Given this list of marker genes CALML4, USP4, HAVCR1, CTDSP2, GIPC1, PRDM1, JADE1, HOXA7, PDE4D, FAM78A, SPAG7, MTTP, PTK2, ZFHX3, CREB3L1, NEBL, NDP, NR2F2, HRK, FGF13, KCNJ15, DDI1, SLC12A1, PACSIN3, POT1, FES, TNS1 (NCBI Gene Id 7145), DNAJB8, NHLH2, ATP1B4, CELF4, HAUS3, LHFPL1, PDHA2, SMOC1, RNF4, MSTN, SSTR1, PLIN2, TTR, CD55, ERN1, BCOR, PLIN1, FOXN3, AQP2, YIPF7, ATXN7L1, HNRNPD, AHNAK, CSF2, AMMECR1, ENSG00000228919, ATP13A4, ROBO1, PTPRO, ZNF423, TAF2, DOCK9, EPHA2, EBF2 (NCBI Gene Id 90868), S100PBP, CDX1, SLITRK2, NECAP1, RBMS1, TCF7L1, ABRAXAS2, PTH2R, JADE2, NOL4L, IRX4, NLGN2, SERPINA6, PCK1 (NCBI Gene Id 5105), MBNL2, PRG4, EXPH5, HOXB8, MFGE8, ZIC4, POLA1, SORCS1, DMP1, HTR2C, MITF, SOX12, JAZF1, TSHZ3, RARB, COL12A1, SKIDA1, PTGIR, PRDX5, SEMA4A, TMEM178A, SCN1A, ZNF503, SOBP, MNT, TRDN, H3-3B, SFN, SGIP1, TRAF3IP2, NF1, GATA3, CELF2, ERBB3, PRDM13, SLC8A3, CAPN12, ZNF532, VPS37B, LRCH1, MTMR11, KLF14, RHOJ, UBR5, KRT32, DCX, FLI1, LINC00472, S100G, GRM8, SHISA6, PAK1IP1, CDKL5, WNT11, MEA1, KRT23, PALS1, DPYD, RNF17 (ring finger protein 17), DCT, TIMELESS, COL4A6, BOC, HOXB5, TDRD5 (tudor domain containing 5), RAX, ACBD5, NPAS3, TSHZ1 (teashirt zinc finger homeobox 1), CDH6, SLC23A3 (solute carrier family 23 member 3), SGMS2, IL11RA, KLK3, OSR1, MYT1, FGF5, PLA2G2E, LMNA, FERD3L, PXYLP1, MYO15A, IL18, SLC5A10, SMIM8, SLC26A7, KIN, KRTAP19-2, GTF2A1L, NRP1, RPS6KB2, GMCL2, IP6K2, EYA1, MECOM, RUNX3, SLC41A2, SSBP3, GSE1, GRIA3, HSD3B7, SYT4 (synaptotagmin 4), NR1H4, ESRRG, TINAG, KALRN, SEC23B (SEC23 homolog B, COPII coat complex component), CYB5D1, ENOX1, EFNA5, STRN3, HOXA1 (NCBI Gene Id 3198), SLC6A4, HOXC13, ZHX2, TRMT10A, ENSG00000291228, SLC17A2, PAX9, KCND1, SF3B4 (splicing factor 3b subunit 4), PLXNA2, USP32, HOXD1, GRIK3, HOXA10, TPM2, C1QTNF7, CRLS1, FCHSD2, KCNMA1, LEMD1, UBE4B, GDF10, SHCBP1, SMPX, ACTC1, CHST15, BPHL, P2RY12, LLGL2, FAM193B, ADGRB2, NOB1, LBX2-AS1, DPF2, APRG1, GABRA1, ART4, KRTAP19-7, SLC6A20, IGFBP1 (NCBI Gene Id 3484), ACVR1, SV2A, TFAP2C, CNTLN, RREB1, CNIH2, NLGN3, ITGA9, FGF10, PDGFRA, MED13, PBX2, LMO3, TCF21, SSMEM1, LMO4, GDF7, TMEFF1, PCDHGB7, DLL1, DOCK11, SCML2, BNC2, BMP10, CLDN14, PCYT2, FBXL22, TUBB4A, NOS1, LRRN3, NAA38, POLE2, SOX4, ADAM22, KLHL41, LIX1, NSMCE3, EHF, MSI2, ABCA12, TMEM88, AMY2B, ANKRD28 (ankyrin repeat domain 28), PMEPA1, ADAMTSL2, PATZ1, RNF181, DUOX1, PHF21B, HOOK1, SP8, GNAQ, LBX1, KCTD5, GEMIN2, PRDM12 (NCBI Gene Id 59335), CSMD3, OTOP3, FZD4, TRERF1, CHST8, ETF1, SUPT16H, HS6ST2, PURA, CHM, GNRH1, ID3, NEO1, CDIN1, NRAS, RORB, TTYH1, COLQ, CCDC6, WNK1, PHYHIPL, PPP1R16B, ASCL4, BATF2, SLC5A1, BACH2, MPPED2, CHCHD7, CACNG8, NPTX2, KCNJ8, PRUNE2, MRPS18B, KCNIP2, FRZB, ENPP1 (ectonucleotide pyrophosphatase/phosphodiesterase 1), DLG2, DMD, HESX1, PCDH7, KLHL13, SYTL2, CCDC9B, PLAG1 (PLAG1 zinc finger), AP4S1, FEZF2, STAP1, TRPS1, NOL4, FOXB1, RUNX1T1, ZNF827, PRKD3, BAMBI, BHLHE22, CPNE5, PTGER1, RGS13, C1orf87, PALS2, GTPBP1, ROGDI, SSTR4, LHX6, HSPB8, GPR85, RHOBTB1, HOXB3, KIAA1191, KLHL1, ZMYM4, OPCML, FURIN, KRT2, HAND2, PRKCSH, SYTL4 (NCBI Gene Id 94121), STAT5B, FGF20, UNC13B, GSC, RIMOC1, SULF1, KCTD15, PLCD4, PTCH1, GC, KCNH2, NDUFA4, SATB2, RBBP8, CLOCK, EPHB6, SGCA, TMEM179, CYB561D1, ARHGAP18, PCNX4, ZBTB17, ADRA1B, CREB5, TGM6, FSTL1 (NCBI Gene Id 65385), INPP4B, PPP1R10, PABPC5, PIK3IP1, SFSWAP (splicing factor SWAP), NRN1L, RBFOX1, DDX49, ATP5F1C, LMNTD2, CKAP4, RTN4RL1, MCAM, DUSP6, MSRA, GRM3, ACBD6, SRSF2 (serine and arginine rich splicing factor 2), NR2F1, SLC5A2 (solute carrier family 5 member 2), MTF1, ZEB1, ALDH1A2 (aldehyde dehydrogenase 1 family member A2), CXCL14, NUDT21, CCER1 (NCBI Gene Id 196477), FAM117A, RINT1, NECAB3, CCIN, MGAT5B, PDYN, TTLL6 (tubulin tyrosine ligase like 6), EMX2, ALX3, ALG13, AQP11, CA4, NLRP7, RASSF2, GRID2, MARK1, PRKAB1, NFE2L1, GBX2, NSD1, HTR3B, RBMX (RNA binding motif protein X-linked), LRRC4, AQP5, HHIP, MTMR4, RASGRF2 (Ras protein specific guanine nucleotide releasing factor 2), SERPINI2, FRMD5, TACSTD2, KLHL4, CPS1, TLE4, RTN1 (NCBI Gene Id 8108), HOXD8, CLRN1, NPR3, TEX12, RELA, CLUH, KLHDC3, CDC6, NOVA1, CDKN2B, APBA1, ASB4, VAT1, PCNX1, TUBE1, HOXD3, GOLT1A, PKP3, BAZ1A, SLC34A3, MACROH2A1, MARCHF6, UBE2C, NONO, PPP3CB, SLC39A5, TGIF1, HOXB6, GPC4, TERB1, LSM11, FOXP2, COPE, NEUROD6, PITX2, SOX5, TENM1, FGF6, SLC26A3, COL9A1, POU3F4, KCNIP4, KRT81, TRMT112, PYGO2, TMEM164, MMP19, NPM3, ST8SIA2, SH3BP4, KLF6, MEOX2, LMO1, CASC2, PCDHAC2, NR2E1, ARHGDIB, TMEM60 (NCBI Gene Id 85025), CDK14, PDRG1, SEMA4G, ELAVL4, CREBZF, HMGN2, NDNF, AGAP3, HOXA9, GARIN2, CTNND2, CHD5, HNF4A, NXF3, GSK3B, RAB30, BCL9, RAB5B, STAC2, PSMC2, ITGB6, SREK1, C15orf40, RASSF7, SPRED1, ATP5MC1, KIF21A, ODAD3, SLC26A5, CSRNP3, CYTIP, HIPK3, LIMS1, HOXA2, HNF1A, HPN, HOXD10, PHF21A, SIX4, PATL1, LARGE1, GNAT1, RASGRF1, SLC37A4, OTX2, CLC, CLPX, WDR47, HOXA3, SATB1, PPM1E, AKIRIN2, RUNX1, PHOX2B, KLHL5 (NCBI Gene Id 54163), IKZF2, TEX2, ARHGAP22, TEX47, ARPP19, GBF1, MSH5, YBX2, here is a description of the gene set: from publication Xie X, Lu J, Kulbokas EJ, Golub TR, Mootha V, Lindblad-Toh K, Lander ES, Kellis M (PMID 15735639) Comprehensive identification of all functional elements encoded in the human genome is a fundamental need in biomedical research. Here, we present a comparative analysis of the human, mouse, rat and dog genomes to create a systematic catalogue of common regulatory motifs in promoters and 3' untranslated regions (3' UTRs). The promoter analysis yields 174 candidate motifs, including most previously known transcription-factor binding sites and 105 new motifs. The 3'-UTR analysis yields 106 motifs likely to be involved in post-transcriptional regulation. Nearly one-half are associated with microRNAs (miRNAs), leading to the discovery of many new miRNA genes and their likely target genes. Our results suggest that previous estimates of the number of human miRNA genes were low, and that miRNAs regulate at least 20% of human genes. The overall results provide a systematic view of gene regulation in the human, which will be refined as additional mammalian genomes become available. studied in species Homo sapiens Human Gene Set: YCATTAA_UNKNOWN Genes having at least one occurrence of the highly conserved motif M58 YCATTAA in the regions spanning 4 kb centered on their transcription starting sites. The motif does not match any known transcription factor binding site.